The following is a description of a gene set: species: Homo sapiens Any process that stops, prevents, or reduces the frequency, rate, or extent of an adaptive immune response. Human Gene Set: GOBP_NEGATIVE_REGULATION_OF_ADAPTIVE_IMMUNE_RESPONSE, and this is the list of marker genes: AHR, HLA-F, LGALS9, CD69, C4BPA, PTPN6, FOXJ1, IL4R, ARG1, IFNA2, JAK3, SAMSN1, SUSD4, IL27RA, PTPRC, SPN (sialophorin), KLRD1, ASCL2, ZBTB7B (zinc finger and BTB domain containing 7B), RC3H1, SLAMF1, DUSP22, RC3H2, IL1RL1, HLA-G, IL7R, PARP3, CD274, ZC3H12A, CR1, CEACAM1, IL2, PDCD1, UFL1, FCGR2B, CD160, CD80, C4BPB, TNFRSF14, FOXP3 (NCBI Gene Id 50943), HAVCR2, IL33, TNFSF4, PPP3CB, LGALS1, CD46, IL20RB, STAT5A, KLRC1, LOXL3, CR2, USP5, TBX21, IL4I1, BCL6, XCL1, TNFSF18, ALOX15, MAPK3, IFNB1, NDFIP1, LILRB1, HFE, LILRB4, CLEC4G, NCKAP1L, CR1L, SMAD7, TRIM27